Given this list of marker genes ENSA (NCBI Gene Id 51620), MEGF9, BICRA, CSGALNACT2, TMEM131, TAPBP, SSBP2, IFIT1, CELF2, SECISBP2L, FGD6, ICE1, RIC8B, APPBP2, SMURF2, CDK17, CRTAM, WDR41, FYN, ERBIN, TBC1D17, ABTB3, PUM1, FAM234A, CYTH3, CLOCK, HERPUD1, YPEL2, ITPRIP, SLC44A2, CERK, MOB1A, GATA1, SCAF8 (SR-related CTD associated factor 8), VPS16, GUCY1A1, NOP53, SSH2, SYF2, WDR37, RAPGEF6, TSPAN32, GABRR2, PLEKHA1, DOCK8, TM2D1, PRKD2, TMX4, FICD, NKIRAS1, TAFAZZIN, PROSER1, MBD5, CRKL, LCLAT1, MPHOSPH9, CDK5R1, GALM (NCBI Gene Id 2718), GPCPD1, MSL2, SLAMF1, NEDD4L, CSTF2T, PTEN, MEF2A (myocyte enhancer factor 2A), SNRK, ATG5, TOR1B, ZFP1, ARB2A, RNF169, HDAC10, GRIPAP1, DIAPH1 (NCBI Gene Id 1729), IRF4, MTG2, C14orf119, STK38, VWA5A (NCBI Gene Id 4013), ATP7A (NCBI Gene Id 613259), MKNK2, GATAD2B, CASP1, TBC1D4, TSPAN13, FAM50A, MTMR12, ANTXR2, ABCG2, MAP4K3, METTL17, OGT, MED17, RAB14, MAP3K2, TMED4, ZNF507, AKAP9, ZNF451, NXF1, NMB, ARID1B, CCDC61, AGGF1, TSC1, DBNDD2, TNFRSF1B, CXXC1, SMARCA2 (NCBI Gene Id 95083), RAB11FIP2, SEC24A, PRKDC, C3orf70, ZMYND11 (NCBI Gene Id 10771), TMEM230, SCAI, RBM22, ASH1L, PLPP6, MTSS1, TRAT1, CLN5, MYSM1, ATP9B, FBXO32, ACTR10, TBRG1, SMAD3, SLTM, TRIM65, PIAS1, PRDM15, ZNF638, ATXN1L, MON2, STIM2, KDM3B, CACNA2D4, ZNFX1, TRIM33, RNF167, SKI, ABCG1, KIDINS220, SOS1 (NCBI Gene Id 7838), MTMR10, RCN1, ARMC5, DGKZ, HELZ2, TRIM11, SLC25A45, CD38, VPS26A, CD79B, ATG10, TMEM106B, TPGS2, TMEM222, RNF213, CISD2, CYB5A, PHIP, CCDC186, AGO1, UBP1, BTG2, ZSCAN21, MARCHF5, SLC45A4, SPACA1, STAT5A, IL10RB, SUSD6, CSAD (NCBI Gene Id 51380), TENT4B (terminal nucleotidyltransferase 4B), ASXL2, ARHGAP5, MAPK11, MPP1, CXCR5, SYNE1, IL27RA, ANKRD11, ZDHHC15, ASTE1, LCOR, CD83, KRAS, MTERF3, HMG20A, CHST10, TULP4, SERPINC1, FBXL3, CCDC126, IK, DYRK2, MLLT6, here is a description of the gene set: Human Gene Set: GSE14350_TREG_VS_TEFF_UP studied in species Homo sapiens Genes up-regulated in comparison of regulatory T cell (Treg) versus effector T cells. from publication Yu A, Zhu L, Altman NH, Malek TR (PMID 19185518) Interleukin-2 receptor (IL-2R) signaling is essential for T regulatory (Treg) cell development and homeostasis. Here we show that expression of IL-2Rbeta chains that lack tyrosine residues important for the association of the adaptor Shc and the transcription factor STAT5 in IL-2Rbeta-deficient mice resulted in production of a normal proportion of natural Treg cells that suppressed severe autoimmunity related with deficiency in IL-2 or IL-2R. These mutant IL-2Rbeta chains supported suboptimal and transient STAT5 activation that upregulate the transcription factor Foxp3 to normal amounts in natural, but not induced, Treg cells. Using cells T cell obtained from normal C57BL/6 mice and mice harboring Treg cells with impaired IL-2R signaling, gene expression profiling revealed many targets in peripheral natural Treg cells that were IL-2-dependent and a substantial overlap between the Treg cell IL-2-dependent gene program and the Treg cell transcriptional signature. Collectively, these findings demonstrate that a critical, and perhaps minor, subset of IL-2-dependent targets in Treg cells is indexed to a low IL-2R signaling threshold and that a substantial proportion of the Treg cell gene program is regulated by IL-2. CD4 T effector cells also showed many IL-2R-dependent gene and these also overlapped in a distintive manner with the IL-2-dependent genes of Treg cells and the Treg gene signature.